The following is a description of a gene set: Mouse Gene Set: MIR_328_5P from publication Chen Y, Wang X (PMID 31504780) Genes predicted to be targets of miRBase v22 microRNA mmu_miR_328_5p in miRDB v6.0 with MirTarget v4 prediction scores > 80 (high confidence targets). studied in species Mus musculus, and this is the list of marker genes: Gsx1, Klra17, Plppr2, Sec61a2, Rps6kb1, Spred3, Ttc28, Pigt, Eloa, Ankrd13b, Med7, Ginm1, Serpinc1, Prdm8, Kcnab2, Pdgfb, Coq5, Ttyh3, Crtc1 (CREB regulated transcription coactivator 1), Rhog, Rasgef1a, Dennd2a (NCBI Gene Id 209773), Fbrs, Cplx2, Sp7, Hspa12b, Fat3, Efnb1 (ephrin B1), Yipf4, Gatad2b, Mknk2, Kat5, Dnaaf6, Dnmbp, Tfpi, Asic1, Vstm2a, Stambp, Cilk1, Prmt8, Csnk1g1, Ccnd2, Itga5, Vamp2, Dedd2, Shisa6, Tmem26, Rad21